Given this list of marker genes SLC6A4, MAOA, ALDH2, here is a description of the gene set: species: Homo sapiens part of: Neurotransmitter clearance Reactome Pathway: Serotonin clearance from the synaptic cleft Serotonergic neurotransmission affects a wide range of behaviors, from food intake and reproductive activity, to sensory processing and motor activity, to cognition and emotion. One such key regulator is the serotonin transporter (5-HTT), which is observed to remove serotonin released into the synaptic cleft.